Given this list of marker genes SEC61A2, GIT2, QTRT1, ATXN2, TTC33, TMCO1, WDFY3-AS2, SLC66A3, TPBGL-AS1, GRIN1, SEPTIN1, PSMD9, KHDRBS1, LYRM1, MIR1915, B4GALT6, CD276, ZNF428 (NCBI Gene Id 126299), SYNJ2, FECH, BRICD5, MTND5P11, PSMC1, PIWIL4, TRAPPC10, SUSD4, ACBD3, MKS1, HNRNPA0, CBX1, GTF2H1, APBA3, NDOR1, ATP13A1, CCDST, GOPC, POLE, SLC16A1-AS1, FUBP1, MFSD10, MAP7-AS1, TENT4B, MIR4710, LINC01567, SOX9-AS1, CLDN16, ROMO1, JMJD1C, SLC12A7, TMEM178B, AKNAD1, PATZ1, GALNS, SLC22A2, COA8, ITGA4, MBTPS1-DT, BCL2L11, ARID4B, SETBP1, SLC25A36, SNX24, COQ9, MTHFS (methenyltetrahydrofolate synthetase), LYPD1, WDR47, DNAJB4, ARIH1, PLCL1, MPP7-DT, EXOSC3, BIRC2, SH3BP2, HUNK, RERGL, SLC16A1, MYCBP2-AS1, TMEM202-AS1, ELOVL2-AS1, DGAT2, CHRD, IQCH-AS1, DMXL1, AZI2, CBR1, XPO6, THTPA, ANO10, MARCKSL1P2, NCBP1 (NCBI Gene Id 4686), MYBL1, ADGRF3, HNRNPAB, HSDL2-AS1, HSPE1-MOB4, DGKE, TMEM150B, RAB3A, SETBP1-DT, IL1R1, ZCCHC18, IGF2BP3, OLFML2B, EGFEM1P, L3HYPDH, SRSF2, PIGP, AKTIP, COQ8A, RRAGD, EPM2A (EPM2A glucan phosphatase, laforin), MT-TP, RPP38-DT, CCDC88C-DT, MTMR2, SCN8A, NUDT19P3, PSMC5, IDH2-DT, C1orf43, NHSL1-AS1, ERBIN-DT, DUS2 (dihydrouridine synthase 2), ZNF385B, RBBP4 (RB binding protein 4, chromatin remodeling factor), MED31 (NCBI Gene Id 51003), LRRC8D, CDADC1, NAGLU, SYVN1 (synoviolin 1), MOCS1, LMO7 (LIM domain 7), BRAP, STX11, TMX4-AS1, TMEM39B, LRRC8D-DT, CHEK1, CFDP1, CNOT6, ENSG00000223446, IL5, DICER1-AS1, COG1, MTNAP1, RBBP6, PPARG, GTF2I, ROR1, YKT6, PPP2R5A, CTTN-DT, MOSPD2, ARRB1, BAG5, PCNT, CYREN, RNF217, SUV39H2-DT, CDYL-AS1, NOS1AP, FKBP8, TBX2-AS1, STK32A, TEX38, NDUFB10, CCNJL, CCNK, NFIX, NEO1, GUK1, PTP4A2, IER2, PTPRJ, CFAP99, IRF2BP2, AZIN2, FANCA, ACOX3, INO80E (INO80 complex subunit E), CTSH, KCNJ2, FLVCR1, C3orf38 (NCBI Gene Id 285237), RPLP2, GGPS1, MAML1, FKBP10, FRMD8, P4HA3-AS1, SDK1, ENDOV, MT-RNR1, FTSJ3, GSDMA, CBR3, LGI3, KCNK12, MTMR4, EIF5, ZNF721, OGFOD3, ACP6, TRMT9B, DLST, ELOVL7, MLF2, ENTREP3, DUSP22, HEXIM2-AS1, CRACDL, LGR4, ALS2, YBEY, CPD, TP53TG5, ANP32B, NUP85, BCAP29, SLC35B3, ADORA2A, PARP16, HACD3, BCAR3, PHF10, ABCC11, ACOT6, MYLIP, ENSG00000248367, CNIH3, DHFR, PDIA5, PNPLA2, UACA, MICALL1, SCN5A, GMDS-DT, LRIG3, MARK1, RTN1, C2CD5, EIF4A3 (eukaryotic translation initiation factor 4A3), ELL, APLP2, SSU72-AS1, ITGA3, PPP1R1C, AK2, SPOP, PRRT3-AS1 (NCBI Gene Id 100874032), TNNC2, HAPLN1 (hyaluronan and proteoglycan link protein 1), EXOSC10, CCNQ, LIPT2-AS1, PKMYT1, TTC36-AS1, IGHVII-30-1, LINC01842, SPECC1L-ADORA2A, TBC1D8-AS1, TSTD2, CDK12, HDAC2-AS2, RNF213-AS1, ERICH2-DT (ERICH2 divergent transcript), MIR378E, PDCD2L, ARSG, SEPTIN10, SALL1, TTC23, CPLX2, C16orf92, ALKBH5, KCTD20, CDC40, NAE1, DDX3X, AGO3, PSD3, GUSB (glucuronidase beta), MSH3, MRS2, MIR760, GMNN, SEMA6A-AS1, EP300-AS1, ZSWIM6, ZKSCAN5, EMX1, TCOF1, DUSP6, DNAJC1, DGAT2-DT, NDUFS6, ZNF706, IQCE, RAP2B, MAPKAPK5, PDE4A, MRFAP1P1, WDR4 (WD repeat domain 4), CDR2-DT, TBK1, COL6A1, RNF4, SHH, ENSG00000271551, TRAIP, KCNK7, TBC1D8, RIPOR1, DNAJB5-DT, C1QBP, ERAP1, RUNDC3B, ISM1, PYCR2, HOXD8, WAPL, IQCH, AKIRIN1, KCNK1, NCOA1, RN7SL319P, ADCY1, EHD4, KLHL25, PPAN, TUBD1, DDI2, CACNA1G, MIER1, SCAND2P, NCDN, GAS6-DT, MCL1, RPL14, LBHD1, ADAMTS17, PHF21A (PHD finger protein 21A), ARID1B (NCBI Gene Id 645070), ZNF771, TMEM175 (NCBI Gene Id 84286), UROD, KIF21A, SEC31A, PIK3R2, TP53BP2 (NCBI Gene Id 7159), DNM3, PHF5A, PPP2CA, DIP2A, LCN9, CPQ, SFTPC (NCBI Gene Id 6440), COL19A1, ACOT13, ZNF219, RFX2, MYO9B, EDEM1, PXK, FAM120C, BPTF, HIPK3, ADAMTSL3, TP53RK-DT (TP53RK divergent transcript), FUS, OSBPL6, PTPRG, LDHA, ERBIN, RABGAP1L, SLC2A1-DT, ITGB1, GLIPR1L1, FBF1, SLC4A8, ARPC5L, WDR90, DDX19A, NELFA, EFCAB2, CLTB, PTPA, STXBP2, CCDC57, MFN2, HDAC2, INSYN1, LYPD6, USP39, TCP11L1 (t-complex 11 like 1), IQGAP3, TMEM170B, WDFY3, NKX6-1, IGSF9B, B4GALT4, LMO2, NAPA, ABHD5, DOCK7, THAP9-AS1, PLEKHA5, EEF1AKMT1, DDX51, CDH23, ACADS, SNRNP40, NFYC, PNPLA7 (patatin like phospholipase domain containing 7), MARK2, HLCS-AS1, HPS5, AKAP1, SH2D2A, TNKS2-DT, COX8CP1, SENP3, TNIP2, ZNF584-DT, STYXL1, YIPF6, SSU72, HAPSTR1, E4F1, GIPC2, ZBTB8OS, CFAP206, RPS10P29, ELAC2, CCBE1, KLF11, MRPL36, PGM5P4 (phosphoglucomutase 5 pseudogene 4), AKAP7, TRMU, DPP8, PIK3C2B, ANKRD20A8P, PTCRA, NUP153, EFCAB6-DT, MT-TF, EFCAB6, ANKRD13C-DT, SDHAP4, PRPH, ALDH3B1, DBNDD2, LGALS3, LRRC8C-DT, DPYSL3, MIR9-1HG, CDC42BPA, ZNF843 (zinc finger protein 843), YY1AP1, STK32A-AS1, GPN3, ATP5F1D, TMEM203 (NCBI Gene Id 94107), ARPIN-AP3S2, HSD11B2, HTR1B, CHD1, ACAD11, PNRC2, C1orf122, ANKRD13A, IFNGR1 (interferon gamma receptor 1), PDZRN3 (NCBI Gene Id 23024), RBM14-RBM4, RBBP9, DSTNP2, SPEF2, ZCCHC9, RN7SL448P, IL15RA, KRTAP12-1, COL6A3, COL2A1, TCF25 (transcription factor 25), AK5, CKMT2-AS1, LRRC59, CMKLR2 (chemerin chemokine-like receptor 2), EEA1, TTLL1, ZBED5, SCO1, KRT23, ACBD7, CDCA7L, GLS, AANAT, PDCD5, MCCC1, ZNF747-DT, WEE2-AS1, PTBP2, SFT2D2, NOP14-AS1, LRRC4, AMZ2P1, TXNDC15, PPP1R13B, DYNC1LI1, NEMP2, PDCD2, LINC02918, HECTD3 (NCBI Gene Id 79654), TSC22D2 (NCBI Gene Id 9819), MTCO3P12, RN7SKP154, GATAD2A, AGBL5, RASSF1, ZNF786 (NCBI Gene Id 136051), PDP2, ERMP1, MPHOSPH10P1, CALCR, ELAVL1, WIPI2, RP9, USP25, OXSR1 (oxidative stress responsive kinase 1), PEF1-AS1, PPFIA1, RPS7, SMIM13, PPIL4, UBE2D1, SNX9, ZCWPW2, CDR2, SYT9, ATG12, IGFBP3, PNMT (phenylethanolamine N-methyltransferase), MRPL12, CANX, SLC16A6, SV2B, PARP12, YY1-DT, PHRF1, CD320, TSPAN12, NKAIN1, C15orf61, ATXN2-AS, ASH1L, LRRC49, SLC35E1, SNX33, POLR3G, PXT1, HYLS1, SDC1, LACTB, ZFYVE9, MEAF6, AMDHD1 (NCBI Gene Id 144193), SNORA24B, PLBD2, TRIM52-AS1, CAMK2D, SRGAP1, MCM3AP, ADAM15, NDFIP1P1, ZNF483, YY1, IFFO2, DUSP28, MTR, LENG8, PPP4R3A, RMND5B, KRCC1, HDAC4-AS1, TYK2, PDXP-DT, ACAN, UGCG, RC3H1-DT, MBLAC2, ZMIZ2, RABGAP1L-DT, LRRC20, PKP4, CYP51A1-AS1, CRPPA, MTA2, SAMD11, ATPAF1, NBPF1 (NCBI Gene Id 55672), MIR3621, TBX6, DNAJC14 (NCBI Gene Id 85406), TRNP1, EPM2A-DT, JMJD6, CCDC88C, PPIF, LIMA1, MTHFD1L, MAP3K3, MGAT3, SINHCAF, ACAT2, SSBP1, NOD2, AP5M1, EXOSC4 (NCBI Gene Id 54512), ELOA, ZNF398, CALCOCO2, INSYN1-AS1, CLCN6 (chloride voltage-gated channel 6), DSE, CKAP5, TRIM14, PLD1, RBM17, PLCG2, CROT, ATP1B1, TATDN2, CCN2, RCC1, CHSY1, ABCA17P, TAF12-DT, VPS33B-DT, G3BP2, STAG3L5P-PVRIG2P-PILRB, MRPS23, THAP9, ATG10, ARHGAP28 (NCBI Gene Id 79822), CHPF2, RAB23, ZNF697, IRX3, ANKMY1, NGFR, VRK2, YIPF4, LIMS1, LOX, TSSK3, SEPTIN4, HTATSF1, RPL13AP10, STKLD1, TRAPPC3, TPI1, RBM20, NET1, TUBGCP6, BLVRB, CMIP, HAUS8, HDAC4, CDK13, ITGB2-AS1, AURKAIP1, CNRIP1 (NCBI Gene Id 25927), BOC, SAMD4A, MLST8, CXCR6, ZNF584, GYG1, DBI, ARFIP1, NDUFA11, JPX, SIVA1, BCL11A, MFSD8, STAG3L5P, TSPAN9, DAP3, KDM5B, RSPO1, ORMDL1, HSDL2, ATRNL1, AFDN, PARL, MIR762HG, LUC7L, MACF1, RAD50, LRIG3-DT, ADRM1, CDYL, TDP2, EIF4ENIF1, ROCK1, EXOC5, CELSR1, KDM7A, ZDHHC1, ZZEF1, PPP1R8, ITPRIP, ZNF174, ZRANB3, GLCCI1, CTBP2, PCYOX1, CREB1, HOXD3, PPIC, ADAMTS1, ERC1, MT-TL1, PATJ-DT, HDGFL3, AHCYL1, TSEN15, CDC14B, OSCP1, NFATC3, TMEM201, DLG5-AS1, TMEM165, GADD45A, PRKAR1A (NCBI Gene Id 5573), CELF6, TP53TG1, RAD23A, TAGAP-AS1, SRSF1, MBOAT1, ABLIM2, FLT4, MBOAT7, KLHL24, PML, RASIP1, DALRD3, DNM1L, PABPC4, TTC32, NACAD, NDUFV3, DDX42, TRIM37, ZNF331, EDC4, PGD, UBE3A, LMO7-AS1, MIR1302-3, USP4, TMX4, PIERCE1, IGSF11, SLC40A1, MIR3661, SNX21, RPS6KB1, RPS21 (ribosomal protein S21), PSME3, OLIG1, TGFBRAP1, PSMG1, DLL1, STK32C, MAN2A2, OSTM1 (NCBI Gene Id 28962), ADGRG6, THAP10, MACIR, FITM2, MYH10, RGS7, C17orf100, PGPEP1, ASPSCR1, PTTG1IP, TIAM2, TMEM171, MIR3936HG, VSNL1, TTK, MMP25, CYSTM1, TFRC, SOS2, SYN2, GBF1, ZNF74, SELENOS, GDF6, LEF1, MANEAL, COTL1, RASGRF2, MAP3K4-AS1, TXNDC5, ACTR3B, EMBP1, LARP1B, SFXN1, MYO18A, AXIN2, MYL12A, CCN6 (NCBI Gene Id 8838), MTTP, HNRNPU, C2orf76 (chromosome 2 open reading frame 76), NOC4L, PRR5, PNKD, HIVEP3, DBNL (NCBI Gene Id 28988), MAP7D1, HMGB3P22, PTP4A1, PDK3, AP3S1, SPRY1, ABCB10, TARS3, URB2, LINC02613, FAM8A3P, CPT2, PLEKHF1, KRI1, MED13L, SMAD5, SRD5A3-AS1, SEPHS2, GPS2, LIPT2, MAPT, SF3B2, DLX6, NLGN1-AS1, PEDS1, C15orf39, ACSL3, EIF2B3, ZNF233, TMTC3, GCFC2, PACS2, RNF13 (NCBI Gene Id 11342), GFER, MTHFR, ICAM3, LENG8-AS1, IGLV3-7, RNF24, LRPPRC, COMMD6, KAT6B, SEMA3F, PGR, LINC01521, KDM2A, GLMN, APTR, DNAJC2, RPSAP31, ITGA11, USP3, TMEM25, HNRNPH1, WDR26, MPC1, BDNF-AS, GORASP2, ITPRIPL2, ZDHHC5, GAK, HIRIP3, RSL24D1, IPO13, SOD1-DT, RSPO3, BECN1, C2orf42, NEMP2-DT, PDCD6IP, JADE3, ZCCHC17, PPP1R3C, AKAP8, GTF2F1, SLC22A5, GON4L, PEAR1, OTUB1, LRRC28, ABHD18, WRNIP1, ZNF155, LINC02901, FBXL3, FDXR, KCTD13, B3GAT1-DT, MYB, MKI67, ISG20, ACAD10, RHOBTB3 (Rho related BTB domain containing 3, NCBI Gene Id 22836), MDM4, PRKAR2A-AS1, SNX30-DT, EIF4A1, PPAN-P2RY11, SNRNP70, RLIG1, NPPB, ACAP2, BTNL12P, MYO1B, APRT, SAMD5, ZNF264, UPF1, CD68, SPATA18, LMAN2, ZNF615, HSPD1, LETR1, AACSP1, NBPF3, C5orf24, UBAP2L, FAM234B, PDXDC1, BMPR1A, CDK5RAP1, PRELID3B (NCBI Gene Id 51012), FAM169A, KIAA1958, ZXDC, GLUL (NCBI Gene Id 2752), SUV39H2, MARCHF5, FAM184A, DEGS1, LINC02482, FAM200A, FLCN, CADM2, CATSPER2P2 (NCBI Gene Id 100420685), ABCB6, TTLL7, MT-ND1, ZNF134, NME1, ESYT2, RAB40C, TRIM52, C7orf25, NIPAL2, SEMA4B, PWWP2A, PNLIPRP1, UBTF, FLVCR1-DT (NCBI Gene Id 647824), ASCC3, PRDM2, CEP290, TMEM248, TMEM198B, SELENOI, FEZ1, TMEM50B, SHISAL2B, TTC32-DT, TRIM11, IMP3, DUX4L17, DOC2A, AP3D1, MYOSLID-AS1, F3 (NCBI Gene Id 99486), ABL2, AGGF1P9, STUB1, NEIL1, PEX6, CEP89, FSCN1 (fascin actin-bundling protein 1), KCTD13-DT (NCBI Gene Id 107984836), DMXL1-DT, COL4A1, A1BG-AS1, CCDC18-AS1, RNF19B, RPS6KL1, ATP6V1G2, C10orf143, AMZ2, TSEN54, TBX2, GEMIN5, PALS2, GPRC5C, PSMB4, RAVER2, KIF3A, SAFB, PRMT7, NSG1, NFKBIZ, LINC01763, SCAANT1, PIBF1, RALGPS2, RHBDF2, PHACTR2, MKNK1, MXD1, HEXIM2, MTCL2, ADAP2, POLG, PKD2, PTBP3, UTP14A, FOXJ2, PLA2G4E-AS1, MAG, NIPSNAP1, RSBN1L, LONRF1, DLX2-DT, TMEM114, YPEL2, ACOT7, PKIG, SMAD3-DT, MEAK7, NHSL1, RCAN1, MEGF8, USP47, PNPLA8, ZNRF2, RSAD1, FZD8, CASD1, STYX, CLSTN2, CRTC3, CLASP1-AS1, MAPK9, DHX30, UROS, HSD17B14, RGS6, ERI2, SLC9A3-OT1, FAM174C, ICAM5, SESN1, ZSCAN32, SEMA6D, PAQR9, NOL8, DCUN1D3, MAT2A, CEP43 (NCBI Gene Id 11116), RGMA, IL6ST-DT, TRIM47, DLX1, SIX4, ECHDC2 (NCBI Gene Id 55268), SRM, HPSE, ENSG00000261840, WDR25, FLJ38576, DNAJB5, FOXF2, RNF187, CCDC38, AEBP2 (NCBI Gene Id 121536), TSEN34, LINC02593, GPR182, PPIA, LINC00269, CCNYL1, ANGPTL6, METTL23, ZNF329, CAMK2G, PLCG1, ELOVL2, TACO1, UBE2Z, XBP1, HELZ, PRICKLE1, LRRC8C, SRSF10, IMPDH1, ST6GALNAC3 (ST6 N-acetylgalactosaminide alpha-2,6-sialyltransferase 3), ZYG11B, NUDCD2, PAG1, FJX1, MAST1, VCF1, C5orf63, SLFN5, WDR45B, CFLAR, DRC3, UAP1L1, ZC3HAV1, BIVM, PSEN2, CENPP (NCBI Gene Id 401541), FOXJ3, BCCIP, AKAP1-DT, SPTBN4, MGAT1, ZNF566-AS1, SIGMAR1, CBR3-AS1 (CBR3 antisense RNA 1), RPL13P5 (NCBI Gene Id 90564), CNEP1R1, PLSCR3 (phospholipid scramblase 3), FANCB, CDCA8, RELA, B3GALNT2, PINK1, STARD8, OBSL1, AGA, PPP2CA-DT, SLC4A8-AS1, BCL9, CLN5, UHMK1, TUBB2A, HEATR3-AS1, WTAP, CPEB3, DAG1, SLC22A23, IMMT, PITPNC1, DRD1, BRF1, OTOA, DYNLT1, USP33, PHOSPHO1, TAB2, ZFP1, CAPN5, MAST3, FLJ13224, SPRY4, AIG1, CAMK4, SURF4, CTR9, INO80B, LAGE3, SLC25A24, ACTR2, PATJ, SLC7A6OS, TRMT10A, PAWR (NCBI Gene Id 5074), PPA1, SLC9A3R1-AS1, RAD52, LINC01596, AFDN-DT, INO80B-WBP1, PAXIP1, ARV1 (NCBI Gene Id 64801), ZFYVE28, ZBTB2, CIT, LDHB, EGLN1, BRAF, BNIP3, LINC01011 (NCBI Gene Id 401232), AOPEP, PCSK6, PYGO2, SPRY4-AS1, HMOX2, MAPKAPK5-AS1, HMMR, SENP8 (SUMO peptidase family member, NEDD8 specific), CEP57L1, ZNF613, AFF1, BMI1, ZNF345, NRG2, NYAP1, MEF2D, RERE, UBA5, ZNF337-AS1, ITPR1-DT, PHC2-AS1, PALM, H2BC26, RAB7A, NUP133-DT, MFSD11 (NCBI Gene Id 79157), GCAT, HEXD (NCBI Gene Id 284004), MIR6720, MICU3, TAF12, WASH3P, STX10, OSMR (NCBI Gene Id 9180), GPSM2, DPM1, SEC61A1, TUBA1C, CENPT, MBTPS1, MDH2, PEDS1-UBE2V1, TMEM135, HBEGF, CCDC47, GALNT2, P3H4, SLC66A2, MAP1LC3B, ASNS, LRP4-AS1 (NCBI Gene Id 100507401), SRCAP, NGRN, STUM, MISFA, RBM14, DYNC2I2, TRBV17, DNER, PKM, MRFAP1L2, C4orf36, VTI1B, PAQR9-AS1, ACD, EGLN1P1, POLD3, COL4A2, ARPIN, ALKBH7, PICART1, CYB5D2, SLC35F3, PTPN18, PRR7 (NCBI Gene Id 80758), RRM2, HPS6, EZH2, PPP6R1, RAG1, PWP1, KCNS3, INKA2, HDAC7, LINC01703, JKAMP, GPR180, AKAP8L, DIPK1A, COL20A1, GALT, NCOR1, ANKRD6, QKI, WEE1, DNAH14, SLC24A4, MFSD4A (major facilitator superfamily domain containing 4A), LRATD2, JPT1, HSPE1 (NCBI Gene Id 82869), HLCS, CGGBP1, PMS1, KLHL18, UCHL3, NUDT19-DT (NCBI Gene Id 118827810), DYNLT2, DICER1, MED15, FMNL2, COBLL1, FAM217B, FAM230G, IFNAR1, STRADB, C1orf50, BMP4, ABCA11P, PRC1, AK4, ASIC3, RNU4ATAC, ABCA3, MIR1258, SFMBT1, SFSWAP, PLCB2, PEX11B (peroxisomal biogenesis factor 11 beta), RPLP1, RANBP2, DENND4C, DDX19A-DT, YTHDF2, PROKR1 (NCBI Gene Id 151012), KLHL11, ST20-MTHFS, SLC22A4, RPAP2, ADPGK, PSMC2 (NCBI Gene Id 5701), PPFIA3, PADI1, PRRC1, MPC1-DT, LINC00963, FAM174B, GLB1L3, LYSET, SCAF8, C7orf57, OST4, ZNF655, USP13, GCLM, PRELID1, NMRAL1, ZDHHC23, TM9SF3, CHPT1, PKN2, IPO5, NKAIN2, GNB4, MYO9A, CDC27, LSM14A (NCBI Gene Id 91161), KIF9 (NCBI Gene Id 64147), TRAK2, ELAVL4, AIFM1, here is a description of the gene set: species: Homo sapiens Genes containing one or more binding sites for (ZNF224) in their promoter regions (TSS -1000,+100 bp) as identified by GTRD version 20.06 ChIP-seq harmonization. Human Gene Set: ZNF224_TARGET_GENES from publication Yevshin I, Sharipov R, Kolmykov S, Kondrakhin Y, Kolpakov F (PMID 30445619)